The following is a description of a gene set: species: Mus musculus Dermatan sulfate biosynthesis Mouse Gene Set: REACTOME_DERMATAN_SULFATE_BIOSYNTHESIS, and this is the list of marker genes: Vcan, Bcan, Dsel (dermatan sulfate epimerase-like), Dse, Ust, Cspg4, Bgn, Chst14, Cspg5, Dcn